Given this list of marker genes RPS8P6, RN7SKP144, CNTN4-AS1, ENSG00000235978, MIR4790, GRM7-AS3, ITPR1, GRM7-AS1, ARL8B, RNU6-1194P, MRPS36P1, ENSG00000189229, PNPT1P1, CD24P5, EGOT, RPL23AP38, UBTFL8, MTARC2P1, IL5RA, CNTN4-AS2, MRPS10P2, EDEM1 (ER degradation enhancing alpha-mannosidase like protein 1), BHLHE40, CRBN, CRB3P1, RNF10P1, ITPR1-DT, LINC01266, BHLHE40-AS1, SETMAR, RN7SL120P, CHL1-AS1, CNTN6, HINT2P1, LINC01986, RPSAP32, LRRN1, DNAJC19P4, CNTN4, RPL23AP39, TRNT1, RN7SL553P, GRM7, RPL21P17, CHL1-AS2, SUMF1, YWHAQP10, CHL1, GRM7-AS2, here is a description of the gene set: Human Gene Set: chr3p26 studied in species Homo sapiens